The following is a description of a gene set: species: Homo sapiens Any process that stops, prevents, or reduces the frequency, rate or extent of the Wnt signaling pathway. Human Gene Set: GOBP_NEGATIVE_REGULATION_OF_WNT_SIGNALING_PATHWAY, and this is the list of marker genes: KREMEN1, SHISA3, FZD1, DKKL1, TMEM170B, MLLT3, NKD2, APCDD1, GLI3, NPPA, FZD6, GLI1, TLE1, TSKU, DACT3, WNT11, NOG, GSC, IGFBP6, CHD8, CER1, RUVBL2, GSK3A (NCBI Gene Id 2931), AXIN1, MIR498, WWOX, AMFR, TMEM64, TPBGL, SDHAF2, NKD1, TMEM88, CBY1, HMGXB4, NHERF1, MIR199A1, STK4, CTNNB1, CSNK1E, MAPK14 (mitogen-activated protein kinase 14), TMEM131L, TBX18, CITED1, LZTS2, UBAC2, MDK, LMBR1L, SOX2, VGLL4, MIR29C, CSNK1A1, IFT80, LRP1, TLE3, FERMT1, TLE2, APOE, WWTR1, PTPRO, HDAC1, CXXC4, SOX30, SNAI2, IGFBP4, MCC, NXN, STK3, SOX17, RNF43, BARX1, DACT1, BICC1, DAB2, PFDN5 (prefoldin subunit 5), MIR203A, CAV1, ISL1, SOX9, FRMD8P1, RNF213 (ring finger protein 213), APP, DKK2, SOX13, LIMD1, GRB10, C12orf43, BMP2, SHISA6, ALPK2, NPHP3, SFRP5, ANKRD6, PPP2R3A, FUZ, LRP4, DKK3, HMGA2, IGFBP1, HECW1, CCDC88C, FRZB, PRICKLE1, FOXO1, APC, CSNK1A1L (NCBI Gene Id 122011), SOSTDC1, TAX1BP3, TLE5, DAB2IP, SHH, SFRP1, CDH2, FGF9, CTHRC1, NOTCH1, NOTUM, DKK4, MAD2L2, DKK1 (NCBI Gene Id 22943), INVS, GSK3B, AXIN2, STK11, AMER2, TRABD2A, SMAD4, PPP2CA, TCF7L2, TMEM88B, MIR29B1, EMD, PRKN, NPHP4, SCYL2, DDIT3, AMER1, OTUD5, WNT5A, LATS1, WNT5B, NKX2-5, MESP1, GREM1, IGFBP2, MDFI, TLE7, RBX1, SFRP4, JADE1, G3BP1, TPBG, HIC1, APC2 (APC regulator of WNT signaling pathway 2), SOX10 (NCBI Gene Id 8223), GPC3 (NCBI Gene Id 6394), SIAH2, EGR1, SFRP2, CTNNBIP1, SHISA2, MIR19B1, DRAXIN, TMEM196, MIR212, LATS2, FOXO3, WIF1, RBMS3, RACK1, SIX3, TRABD2B, NFATC4, MIR665, NLK, TSC2, TLE4, PTPRU, MIR1-1, CYLD, TLE6, APCDD1L, ZNRF3, SOST, FRMD8